Given this list of marker genes C1QB, C4B, C8B, C1S, CFB, C8A, C2, MASP2, CD55, CFP, C4A, C8G, CFD (NCBI Gene Id 1675), C6, C1QA, C7, C5, C3, C9, MASP1, C1R, C1QC, here is a description of the gene set: Human Gene Set: WP_COMPLEMENT_ACTIVATION species: Homo sapiens Complement activation